Given this list of marker genes LRTM1, SVEP1, TNKS1BP1, MFSD4A, FFAR2, HCST, NPTX1, SCARA5, BBS2, WDR26, TMEM114, CRIPTO, MYADM, BATF, SERPINA5, SYT10, STK25, FLACC1, NIBAN2, KRT81, ELL3, TBX21, HYAL4, SALL1, NTNG1, HOPX, ANK3, ACOT12, ART3, CCNL1, GAS1, ANKS4B, TAS1R2 (taste 1 receptor member 2), ZNF2, SLFNL1, ELF3, ENGASE (NCBI Gene Id 64772), LMO2, C20orf141, SMPDL3A (sphingomyelin phosphodiesterase acid like 3A), ADORA1, COL6A1, CNKSR2, ARSB, CILK1, ENOX1, CASP4, KLF17, EDA2R, NMBR, TREML4, SLC27A5, NOL6, TGM5, SLC22A13, RASEF, GLDC, GPR39, CPSF4L, ARHGEF2, LRCH2, GPR15, FKBP6, GJA4, CASR, ACSF2, IFNG, G6PC2, SLC16A13, ADD2, MSRB3, PNMA8A, MARCHF3, TNS2, IBSP, TCEA2, CPNE2, RGS1 (NCBI Gene Id 5996), ABRAXAS1 (NCBI Gene Id 84142), PRSS46P, HDHD5, ANKRD13D, IL5, SNCA, CAPSL, HEPACAM2, IL6R, EML1, CCL4, RGMA, TUBB6, COMP, GSTO2, PLEKHG3, PLXNA4, IL17RC, PLD2, SPMIP9, GSX1, HTR7, RAB38, FGF7, COA4, TMEM74B, CDH16, IL6ST, SLC6A14, HTR1B, ZC2HC1C, HOXD3, CELF6, VIT (vitrin), SPIB, CD248, TRPC7, GPIHBP1, CPVL, DNAH2, OPLAH, DYM, STING1, MS4A1, EGFR, IL36B, ANKS1B, FUZ, SPRR2A, MAN2B1, FNDC11, KLK8, PNLIP, PRKCE, TOR1AIP1 (NCBI Gene Id 84764), MYO7A, GCHFR, RAB3GAP2, CD22, UPK3A, STAR, SPINK8, SYCP2, POU6F1, PENK, LRFN1, TMEM127, LMO1, KCNJ10 (NCBI Gene Id 3766), HES2, FRG1, CCR2, HOXC4, WFS1, TOMM40L, TEX19, RAB3D, NAGS, C5, MERTK, NHLH2, DLK1, MVD, CLCN5, FBLN7, OXT, SPRTN, DGKH, CYBB, BAHCC1, PSAPL1 (NCBI Gene Id 768239), SLC44A3, NT5DC3, ADAMTSL1, SAG, TRABD2B, FCGR2B, SLC16A7, FAM229A, CCR9, FITM1, MEIS2, ZNF169, RAB31 (NCBI Gene Id 11031), SLC16A11, FZD9, LCP1, CCDC136 (coiled-coil domain containing 136), TGIF2LX, TMEM269, GTSF1, KLRK1, NREP, MGAT4B, NKX2-8, SNRPN, SCRN1, DBX1 (developing brain homeobox 1), DPYSL3, MPHOSPH9, TTC39B, here is a description of the gene set: Human Gene Set: GSE2770_IL12_AND_TGFB_VS_IL4_TREATED_ACT_CD4_TCELL_6H_DN from publication Lund R, Aittokallio T, Nevalainen O, Lahesmaa R (PMID 14607935) species: Homo sapiens Genes down-regulated in CD4 T cells activated by anti-CD3 and anti-CD28: TGFB1 and IL-12 (6h) versus IL4 (6h). Th1 and Th2 cells arise from a common precursor cell in response to triggering through the TCR and cytokine receptors for IL-12 or IL-4. This leads to activation of complex signaling pathways, which are not known in detail. Disturbances in the balance between type 1 and type 2 responses can lead to certain immune-mediated diseases. Thus, it is important to understand how Th1 and Th2 cells are generated. To clarify the mechanisms as to how IL-12 and IL-4 induce Th1 and Th2 differentiation and how TGF-beta can inhibit this process, we have used oligonucleotide arrays to examine the early polarization of Th1 and Th2 cells in the presence and absence of TGF-beta after 0, 2, 6 and 48 hours of polarization.